Given this list of marker genes Jun, Hspa1b, Zfp36l2, Klf6, Btg2, Fos, Tsc22d3, Junb, here is a description of the gene set: Genes negatively differentially expressed in cell type: CD4+ T cell upon treatment with cytokine: IL-27 in mouse lymph nodes in vivo. from publication Cui A, Huang T, Li S, Ma A, Pérez JL, Sander C, Keskin DB, Wu CJ, Fraenkel E, Hacohen N (PMID 38057668) Cytokines mediate cell-cell communication in the immune system and represent important therapeutic targets. A myriad of studies have highlighted their central role in immune function, yet we lack a global view of the cellular responses of each immune cell type to each cytokine. To address this gap, the authors created the Immune Dictionary, a compendium of single-cell transcriptomic profiles of more than 17 immune cell types in response to each of 86 cytokines (>1,400 cytokine-cell type combinations) in mouse lymph nodes in vivo. A cytokine-centric view of the dictionary revealed that most cytokines induce highly cell-type-specific responses. For example, the inflammatory cytokine interleukin-1β induces distinct gene programmes in almost every cell type. A cell-type-centric view of the dictionary identified more than 66 cytokine-driven cellular polarization states across immune cell types, including previously uncharacterized states such as an interleukin-18-induced polyfunctional natural killer cell state. Mouse Gene Set: CUI_T_CELL_CD4_IL27_RESPONSE_DN studied in species Mus musculus